Given this list of marker genes Ncor2, Hdac11, Hdac8, Hdac4, Tbl1x, Hdac7, Snw1, Notch3, Hdac10 (histone deacetylase 10), Hdac3, here is a description of the gene set: part of: Generic Transcription Pathway species: Mus musculus This event has been computationally inferred from an event that has been demonstrated in another species.<p>The inference is based on the homology mapping from PANTHER. Briefly, reactions for which all involved PhysicalEntities (in input, output and catalyst) have a mapped orthologue/paralogue (for complexes at least 75% of components must have a mapping) are inferred to the other species. electronically inferred by orthology from the curated human pathway Reactome Pathway: Notch-HLH transcription pathway